The following is a description of a gene set: Cancer cells differentiate along specific lineages that largely determine their clinical and biologic behavior. Distinct cancer phenotypes from different cells and organs likely result from unique gene expression repertoires established in the embryo and maintained after malignant transformation. We used comprehensive gene expression analysis to examine this concept in the prostate, an organ with a tractable developmental program and a high propensity for cancer. We focused on gene expression in the murine prostate rudiment at three time points during the first 48 h of exposure to androgen, which initiates proliferation and invasion of prostate epithelial buds into surrounding urogenital sinus mesenchyme. Here, we show that androgen exposure regulates genes previously implicated in prostate carcinogenesis comprising pathways for the phosphatase and tensin homolog (PTEN), fibroblast growth factor (FGF)/mitogen-activated protein kinase (MAPK), and Wnt signaling along with cellular programs regulating such 'hallmarks' of cancer as angiogenesis, apoptosis, migration and proliferation. We found statistically significant evidence for novel androgen-induced gene regulation events that establish and/or maintain prostate cell fate. These include modulation of gene expression through microRNAs, expression of specific transcription factors, and regulation of their predicted targets. By querying public gene expression databases from other tissues, we found that rather than generally characterizing androgen exposure or epithelial budding, the early prostate development program more closely resembles the program for human prostate cancer. Most importantly, early androgen-regulated genes and functional themes associated with prostate development were highly enriched in contrasts between increasingly lethal forms of prostate cancer, confirming a 'reactivation' of embryonic pathways for proliferation and invasion in prostate cancer progression. Among the genes with the most significant links to the development and cancer, we highlight coordinate induction of the transcription factor Sox9 and suppression of the proapoptotic phospholipid-binding protein Annexin A1 that link early prostate development to early prostate carcinogenesis. These results credential early prostate development as a reliable and valid model system for the investigation of genes and pathways that drive prostate cancer. species: Mus musculus from publication Schaeffer EM, Marchionni L, Huang Z, Simons B, Blackman A, Yu W, Parmigiani G, Berman DM (PMID 18794802) Mouse Gene Set: SCHAEFFER_PROSTATE_DEVELOPMENT_48HR_DN Genes down-regulated in the urogenital sinus (UGS) of day E16 females exposed to the androgen dihydrotestosterone for 48 h., and this is the list of marker genes: Gypc, Pten, Prox1, H2-M3, Tsix, Armcx6, Epha5, Slc1a3, Enpp1, Fam181b, Ptchd4, F730043M19Rik, Ednra, Sh3pxd2b, Stfa1, Slc1a1, Crocc, Tspyl5, Abhd8, Thbs1, Gas1, Cbfa2t2, Arhgap25, Nuak1, Stard9, Krtdap, Egln3, Ebf3, Cdc42ep3, Lrfn5, Slc1a6, Nr4a2, Ccdc74a, Papss1, Filip1l, A930004D18Rik, Cd55, Gabra4, Slco2b1, Eif2s3x, Rhbdl3, Avpr1a, Sufu, Zeb1, Lysmd2, Cdh6, Ms4a7, Dpp10, G6pc2, Tcerg1l, Dusp7, Sox17, Ttyh3, Ctsb, Loxl1, Pde1a, Dubr, Tril, Ahr, Socs1, Cracd, Csta2, Eln, Ddr2, Bcat1, Gm16485, Kcna4, Pkp4, Isoc1, Qpct, Srebf1, Il1r1, Antxr1, Slit2, Gm6213, Cstdc4, Tgfb1i1, Gria1, Arhgap42, Dab2, Dhrs7, Slitrk1, Angptl6, Hs3st4, Lbp, Cenpe, Caln1, Tent5a, Kif26b, Timd2 (T cell immunoglobulin and mucin domain containing 2), Large1, Cdh10, Rab7b, Laptm4b, Ipo11, Rab3b, Glis2, Igf1, Rnd3, Ephb1, Mycn, Pi4ka, Zswim6, Rassf2 (NCBI Gene Id 99374), Lhpp, Iigp1, Amhr2, Cckar, Zfp36l1 (zinc finger protein 36, C3H type-like 1), Fam171b, Vsir, Rxfp1, Col8a1, S100g, Skida1, Neto1, Fam13a, Ntng1, Edil3, Inhba, Il17rd, Cdip1, Sox7, Ctps2, Adamts18, Cxcl13, Ptger3, Eif2s3x-ps1, 1700017B05Rik, Ar, Robo2, Map4k5, Gabra1, Chsy3, Colec10 (NCBI Gene Id 239447), Dnai4, Dab2ip, Rtn4r, Mbd1, Cd248, Stxbp6, Nbea, Rhoj, Nfix, Mmp16, Creb5, Runx1t1, Trpc6, Cables1, Rassf4, Armcx3, Zmat4, C1qtnf7, Chdh, Bmp2k, Padi4, Zfp536, Wfdc2, Fnbp1l, Slc14a1, Msx2, Epha7, Cachd1, Lypd6b, Emilin3, Nr0b1, Sertad2, Spon2, Ly6d, Aqp1, Ppp1r3b, Grem1, Krt75, Med13l, Blnk, Adamts19, Pex5l, Pnliprp1, C9orf72, Cfap418, Jund, Kndc1, Enpp3 (ectonucleotide pyrophosphatase/phosphodiesterase 3), Cntn1, Abcc9, Mfap2, Esr1, Ccl11, Snx20, Rybp, Adgrl3, Chrna4, Tmem132c (transmembrane protein 132C), Adamts8, Samd5, Dusp2, Prtg, Pamr1, Cacna1g, Prkcb, Mfap4, Kdm5c, Eya2, Gabrb1, Rhobtb2, Rbpj, Adam23, Atp2b1, Dynlt5, St3gal4, Mamstr, Kdm6b, Mmp3, Anpep, Mcur1, Pmepa1, Mup1 (major urinary protein 1), Itga4, Prkd3, Pabpc4l, Nedd9, Cd300c2, Cttnbp2, Sdc2, Rev3l, C1qa, Scx, Serpinf1, Fgf18, Fbxl7, Klf10, Adgra1, Srgap1, Id4, Tspan2, Sh3bp5, Pbdc1, Akap5 (NCBI Gene Id 70774), Maco1, Rbbp9, 9530013L04Rik, Gabrg3, Cyria, Lyz2, Ankrd6, Armcx2, Zfp521, Cd83, Shisa2, Sulf1, P4ha2, Ahdc1, Pde1b, Trpm5, Gpm6b, Pacrg, Xist, Dach2, Slc26a7, Irf2bpl, Myb, Pde4dip (NCBI Gene Id 97109), Slc16a3, Asns, Kcnk9, Dgkh, Meis1, Camkk2, Gucy1a1, Arid5b, Tgfb3, Cacna2d3, Sh3kbp1, Slc1a4, Syt13, Lhfpl3, Ldb2 (LIM domain binding 2), Msrb2, Rec8, Igdcc4, Pip4k2b, 4930449I04Rik, Foxp1, Pknox1, Prex1, Onecut2, Klf7, Prrx1, Myh10, Pcdh10, Ppm1a, Naprt, Bmf, Tgfbi, Ubash3b, Dgat2, Mrgprf, Gabrb2, Sipa1l2, Btd, Ralgds, Cdca7, Lmo3, Arl4c, Lmna, Gas2l3, Irf1, Wnt7a, Rbms3, Rnf152, Cd55b, Zfp704, Crabp1, Ddx3x, Kcnab1, Sema5b, Pdlim7, Spats2l, Fam8a1, Stfa3, Wasf1, Mex3b, Dcc, Hspa1a, Rerg, Rimkla, Dbx2, Mab21l3, Parm1, Oxct1, Pthlh, Mmp10, Bmp3, Prr5l, Dixdc1, Cpxm2, Negr1, Cdkl1, Bst2, Runx1, Pcdh18, Fam107b, Galnt14, Lonrf1, Muc15, Stfa2l1 (NCBI Gene Id 268885), Tgfbr2, Ndrg1, Pkd2, Dzank1, Gucy1b1, Elovl6, Synpo2, Rspo1, Tspan18, Comtd1, Hdac4, Matn2, Lrfn2, Lgmn, Phactr1, Cntnap4, Ablim2, Aldoc, Ryr3, Krt17, Ccdc80, Copg1, Entpd4, Abi2, Smad5, St3gal2, Fem1b, Foxj3, Gad2, Adgrb2, Ntrk2, Kazn, Pcdh19, Slc7a10, Larp1, Hirip3, Gfod1, Fam131a, Pdgfrb, Fibin, Tsn, Chst9, Per2, Sparcl1, Kctd1, Amph, Tmem213, Tiam2, Stk3, Hivep2, C1qc, Pcdh20 (protocadherin 20), Bach2, Camkv, Pappa (NCBI Gene Id 71487), Nrros, Fbln1, Erc1, Tcf4, Klf12, Wfikkn2, Gprasp1, Nrp2, Mif, Rspo2, Pla2g12a, Def6, Palld, Grin3a, Slc19a2, Foxo6, Bcor, Tyrobp (NCBI Gene Id 22177), Kifap3, Elac2, Tmem132e, Igfbp4, Plxdc1